Given this list of marker genes SNX18, NIPAL4, SEL1L, MBLAC1, CDH5, QKI, TMEM135, PCDH7, CNTNAP1, LANCL3, SRF, SLC35A4, RBAK, TMEM132E, ATXN1, OLAH, SH3BP2, CBFB, MCPH1, CDKL5, ZBTB11, IQSEC3, BAK1, DUS1L (NCBI Gene Id 64118), ZSWIM6, PRICKLE1, ZSWIM4, IRF4, DNAJC14, RASSF3, PHACTR3, INO80D, PHF20, TRMT10B, CBLL1, LURAP1L, RAPGEF5, SUN1, NFYA, DUSP26, ADAR, MXD4, KDM4C, BHLHE41, ITGB2, STARD13, ABCC4, TENT5A (NCBI Gene Id 55603), RFX5 (regulatory factor X5), JADE3, LRRC59, EFCAB14, DUSP6, GJA1, EXTL3, IGSF3, SBNO1, HMGCLL1, UBASH3B, CFAP141, BCL2L2, PI4K2B, SH3TC2, GCNT1, ASXL3 (NCBI Gene Id 80816), KDM7A, BBC3, ABHD6, DISC1, ZBTB37, ENPEP, ZFAND1, LGALSL, TAOK1, PPP4R3A, ZKSCAN5, PGRMC2, UBR7, IER3IP1, ZNF704, RBM20, DOCK3, USP38, UBR2, HNF4G, SYDE2, ALCAM, here is a description of the gene set: species: Homo sapiens Genes predicted to be targets of miRBase v22 microRNA hsa-miR-4732-3p in miRDB v6.0 with MirTarget v4 prediction scores > 80 (high confidence targets). Human Gene Set: MIR4732_3P from publication Chen Y, Wang X (PMID 31504780)